The following is a description of a gene set: Enables the transfer of organic cations from one side of a membrane to the other. Organic cations are atoms or small molecules with a positive charge that contain carbon in covalent linkage. studied in species Mus musculus Mouse Gene Set: GOMF_ORGANIC_CATION_TRANSMEMBRANE_TRANSPORTER_ACTIVITY, and this is the list of marker genes: Slc47a2, Slc22a2, Slc25a26, Slc38a3, Slc38a7, Slc22a1, Slc6a20a, Slc25a19, Slc16a9, Slc22a15, Slc7a2, Slc25a17, Slc29a3, Slc1a5, Slc1a1 (solute carrier family 1 (neuronal/epithelial high affinity glutamate transporter, system Xag), member 1), Slc38a4, Slc32a1, Slc36a2, Slc25a29, Slc44a1, Flvcr2, Slc25a15, Slc29a4, Tspo2, Slc44a4, Slc7a6, Slc38a5, Slc36a3, Slc44a3, Slc7a1, Slc44a2 (NCBI Gene Id 68682), Slc22a21, Aqp8, Slc36a1, Rhag, Slc25a42 (solute carrier family 25, member 42), Slc38a9, Slc43a1 (NCBI Gene Id 98836), Slc7a5, Slc22a4, Slc43a2, Slc22a5, Slc7a7, Slc25a38, Atp13a3, Slc38a2, Slc36a4, Slc66a1, Slc7a8, Mfsd12, Slc15a4, Slc6a5, Slc22a8, Slc18a3, Slc6a8, Slc5a7, Slc6a9, Sfxn1, Slc38a1, Sfxn3, Slc47a1, Slc6a20b, Slc22a3 (solute carrier family 22 (organic cation transporter), member 3), Slc6a6, Slc6a3, Slc7a3, Slc6a7, Slc25a20, Slc3a2, Slc6a2, Slc19a2, Slc6a14, Slc1a4, Slc25a2, Slc38a6, Flvcr1, Slc19a3, Slc1a2, Slc22a16, Pou2f2, Slc16a10, Slc44a5